Given this list of marker genes GRIA3, GRIA4, GRIN2A, NLGN3, NLGN1, GRIN2D, GRIA2, GRIA1, NLGN2, GRIN3A, GRIN3B, DLG4, GRIN2C, MIR196A2, GRIN1, GRIN2B, NLGN4X, NRXN1, here is a description of the gene set: studied in species Homo sapiens Human Gene Set: WP_NRXN1_DELETION_SYNDROME NRXN1 deletion syndrome